The following is a description of a gene set: Human Gene Set: GOBP_CHROMOSOMAL_5_METHYLCYTOSINE_DNA_DEMETHYLATION_PATHWAY species: Homo sapiens A process that chemically modifies 5-methylcytosine (5meC) to make it a substrate for the base excision repair pathway, which then restores the unmodified cytosine., and this is the list of marker genes: HNRNPAB, TET1, A1CF, SYNCRIP, TET3, TDG, TET2, APOBEC1